Given this list of marker genes Lamtor5, Rraga, Strada (STE20-related kinase adaptor alpha), Rragc, Tsc2, Stradb, Cab39l, Tsc1, Ppm1a, Prkag3, Lamtor4, Mlst8, Prkab1, Rptor, Lamtor3, Prkag1, Stk11, Mtor, Lamtor2, Rragd, Rheb, Prkab2, Prkag2, Cab39 (calcium binding protein 39), Rragb, Lamtor1, Slc38a9, Prkaa1, Prkaa2, here is a description of the gene set: species: Mus musculus Energy dependent regulation of mTOR by LKB1-AMPK Mouse Gene Set: REACTOME_ENERGY_DEPENDENT_REGULATION_OF_MTOR_BY_LKB1_AMPK